The following is a description of a gene set: mouse primary BMDCs were stimulated with tlr ligands and gene expression changes were profiled on Affymetrix arrays Human Gene Set: GSE17721_PAM3CSK4_VS_CPG_8H_BMDC_UP studied in species Homo sapiens Genes up-regulated in comparison of dendritic cells (DC) stimulated with Pam3Csk4 (TLR1/2 agonist) at 8 h versus DC cells stimulated with CpG DNA (TLR9 agonist) at 8 h. from publication Amit I, Garber M, Chevrier N, Leite AP, Donner Y, Eisenhaure T, Guttman M, Grenier JK, Li W, Zuk O, Schubert LA, Birditt B, Shay T, Goren A, Zhang X, Smith Z, Deering R, McDonald RC, Cabili M, Bernstein BE, Rinn JL, Meissner A, Root DE, Hacohen N, Regev A (PMID 19729616), and this is the list of marker genes: KCNJ2, IFTAP, COX19, CLUH, MYO18A, SPATA13, COQ9, AAMDC, MRPL2, GTF3C5, COL5A1, PDF, FCHO1, CTNND1, GALNT3, ACTR1A, EBF1, PHYKPL, INTS6L, RNASEH2C, PRMT7, SRXN1, ANAPC13, LDB2, PC, COMT, LPIN3, MYO1C, DNAJC3, SACM1L (NCBI Gene Id 22908), PRR13, CFAP410, C1QBP, CLIC1, DGAT2, MATN4, CYB5R1, SEC62, PTPMT1, NKX3-2, AARS1, TTC27 (NCBI Gene Id 55622), CASD1, COX7A2L, DUSP16, MRPS21, RWDD3, COA6, DDX54, MBOAT7, C16orf74 (NCBI Gene Id 404550), CEP95, RAB7A, XPNPEP1, HSD17B12, GLE1, EMG1, GRK4, NDUFB10, CBR1, MCUB, ALAS1, SREK1, HEATR1, ZNF704, TM9SF3, BRD4, TTC3, CD74, BNIP1, CHRDL2, ALDH1A2, GPS1, CCNI, EIF4B, PUS7, FIG4, CYP51A1, HSD3B1, FRMD6, LMAN1, EMC7, PNPLA7, RNF130, MAFF, NECAP2, CCT5, EXTL3, GLUD1, TSPAN14, CCL17, MRPL35, ARRB2, SEMA3A, RPF2, NOP14, MRPL52, ENTPD4, ARFGEF1, TWIST2, RHOQ, CORO1C, LSM3, CAPN8, TPK1, NKX6-1, NDUFA8, YWHAE, PUM3, ARPC1A, SCN10A, HMBS, PHB1, NF2 (NCBI Gene Id 654093), LONP2, MKI67, WAS, KCNJ1, CARMIL1, RBM28, SYCP1, SYS1, BBLN, DCTPP1, RMND5B, MAP3K6, MRPS7, ADAM9, UBALD1, IP6K1, PCNX4, ATP13A2, EPB41, ANAPC1, SUSD6, CLEC4A, RTCB, IQGAP3, FAM118B, SACS, TMEM141, ADD1, FAM149B1, SNRPG, MRPL41, DAPK1, RPL37A, KRT13, RAP1GDS1, ASB6, SEC63, ACTL7B (actin like 7B), HLX, BCCIP, WDR5, NCKAP1L, TSPAN13, RIN1, EIF2AK4, PIGP, SDC1, TBCEL, DDB1, ABCB11, ZCCHC17, KPNA2, RGL3, FASN, MRPL20, RDH10, TP53INP2, NCKAP5L, TRMT112, NUP210, SERF1A, MAP2K3, RBFOX2, SYK, SPEN, DCUN1D5, NOCT, IMP3 (NCBI Gene Id 64970), TMEM14C, HR, DNMT3L, PLPBP, MRPS17, C11orf86, TREM1, PDCD2, CHKA, GPAA1, RGS19, CD300LD, NUDC, NADK, EMILIN1, NME6, ADI1, ADAMTS10